Given this list of marker genes LY6G5C, KCNH6, ZBTB20, GADD45B, AAK1, ARRB1, EPS8L1, PDE4B, TM7SF3, PPP1R2C, GALNT13, RGS2, CACNA1A (calcium voltage-gated channel subunit alpha1 A), KREMEN1, DUOXA2, NID1, TMEM156, ART4, TFPI, LRRD1, ZSWIM2 (NCBI Gene Id 151112), XCL1, FHL2, LINC03013 (long intergenic non-protein coding RNA 3013), IL13RA1, SH3D21 (SH3 domain containing 21), TFAP2C, TNFRSF14, TNFSF9, GLULP4, TTC39A, SP5, MYH14, MYO7A, OSBPL5, LINC02478, ATP2B3, PPP1R15A, MYO5B, TRAV24, FAM167A-AS1, SMIM34, ANXA8, ZNF286A, JUNB, UBE2H, DSPP, PER3, ZNF451, MIR214, ENSG00000291156, TRPM5, BBOF1 (NCBI Gene Id 80127, basal body orientation factor 1), TPCN1, LINC02549, CD69, HS1BP3, ZNF594, C4orf3, TRIM8, CDC42EP3, CFAP53, PAPPA, ZNF264, EIF4A1, CD7 (CD7 molecule), NRG2, HOXB1, HLA-DQB1, HLA-DOB, PLXDC1, WIPI1, BTD, HOXB13, ATP2C2-AS1, LLGL2 (NCBI Gene Id 3993), MYLIP, FAM226B, CARMIL3, JSRP1, PURPL, LILRA5, VNN1, TPM3, TRIM22, IQCF5, C1RL, PYHIN1, CD44, FBXO44, PDXP-DT, MR1, PTGS1, KCNIP2-AS1, C1QTNF1-AS1, PSORS1C2, TIAM1 (NCBI Gene Id 7074), GCH1, SIPA1L3, NIPAL2, CTC1, KRAS, UNC13D, IFRD1, HS3ST5, GPATCH2L, GABRA6, CMBL (carboxymethylenebutenolidase homolog), DNAJC4, DCANP1, PLK2, RAB3GAP2, BTNL9 (NCBI Gene Id 153579), MIR133A1, TRIM16, LNCARSR, LINC02352, HIPK2, BIN1 (bridging integrator 1), NHIP (neuronal hypoxia inducible, placenta associated), TTC12-DT, SEMA6A (semaphorin 6A), WDR59, RBM43, ITGAM, ADGRA2, MACROH2A2, DGKA, PRELID2, ACACB, ENPP2, ULBP3, EXOC3-AS1, EP400, CP, NFIB, PTCRA, PRKAA2, MAOA, SESN2, TNFAIP6, SPOCD1, MYLK, CCR5, CIMIP4, APOBEC3G, RCBTB2, LYZ, LINC00520, IGFN1, HBS1L, TSGA10, TNP2, LINC00824, MIR34AHG, ZNF91, TJP3, KRT18P27, SYTL1, FAXDC2, LINC00964, FCRL4, OFD1, UBE2F, ENSG00000240207, TP53INP1, GSDMB, GP6, LCP2, PPIC, STK17B, ARPP21, DYNC1I1, PIM1, CASS4, APOBEC3F, ZBP1, LINC00857, LAMA5-AS1, CCNYL2, ZMAT3, FDXR, IKBKB, HOXC8, ABCB9, LINC00550, TRAV40, CAPN13, CDKN1A (NCBI Gene Id 1026), TPPP2, SGK1, CYP19A1, SHANK1 (NCBI Gene Id 50944), LRP6, SLC10A1, PTAFR (NCBI Gene Id 91527), BBC3, FAM20C, IGHE, SAT1, MIR22HG, CLDN1, RAG2, ALOX5, FER1L5, RNF39, ZNF727, HMCN2, MXD1, DEPP1, DLX2, MPEG1, RRAD, HSD11B1-AS1, GPSM1, CAMTA1, EGFLAM-AS2, ZBED2, LINC02941, MON2-AS1, NACA, IL5, DCBLD2, FER1L4, ABAT, EIF1, CX3CR1, SLAMF8, RAB1A, IGHA1, GATA4, DOCK9-DT, SIX1, CREBRF, NR4A3 (nuclear receptor subfamily 4 group A member 3), JUN, FOXE1, TNFRSF10D, MPDZ, PTGER3, ORM1, BNIPL, DAPK2, IL9R, KLK1, VRK3, TSC22D1, SLC6A19, KIF19, AVPR2, PRKD2, EHMT2-AS1, PLEKHG4B, NEAT1, RNF157-AS1, PLEKHH1, RGS1, CA10 (carbonic anhydrase 10), TMEM202-AS1, AP3B2, CD72, WNT9A, THBS1 (NCBI Gene Id 7057), CCL28, ENSG00000261095, MXD4, HAX1, CFAP47, ZNF396, SIK1, HLA-DQA1, GPR85 (NCBI Gene Id 54329), FLT4, BIRC7, PCDHB12, ZMYND10, ADAMTS1, UCP2, SCARA5, IDS, TMEM171, GRM7, ALDOB, RAB4A-AS1, FAM83E, MNX1-AS1, ARSD (NCBI Gene Id 414), ENSG00000289202, KLHL22, ASS1 (argininosuccinate synthase 1), PLCXD2, ICA1L, FBXL19-AS1, MTNR1A, ENSG00000250230, H2AC25, PCYT1B, MAP3K12, THAP10, CASP3, RTF2, ZNF155, S100A7A, KLF6 (KLF transcription factor 6), POU3F1, POLD4, FAM153A, SORBS2, GDF2, SAMD4A, HAGHL, DPYSL5, OR5V1, SLAMF6, SYNE1, ZFP36L1, F11R, C3orf52, RHEB, PABPC1, PYCARD-AS1, LILRB3, UBR5-DT, LINC01649, UBE2V2, INPP4B, MYH1, IGSF3, POC1B-AS1, PRKG2, CYP4F2, PRM1, SLC2A3, ADIRF, SYT17, PHTF2, PLAAT4, SESN1, ID2, TMT1A, PIK3CA-DT, LINC00929 (long intergenic non-protein coding RNA 929), RBBP6, AQP2, FAS, LNCPRESS1, RORB, SLC22A23, ALDH2, NHSL1, CD27, IL7, IL21, HOXB9, LRRC71, TSC22D3, THBS1-IT1, EML2, SERPINA1, RORA-AS1, AK1, FCMR, CD37, TXNIP, PIERCE2, YPEL5, PTPRS, CCDC13, DUSP1 (NCBI Gene Id 1843), SLC2A12, RNF144B, CALD1, FUT6, CELA1, PCDHA9, SATB1, COL2A1, HPGD, PLAC9, CHIC1, LTBR, TP53TG1, BTG1, SV2C, CASC15, GADD45A, PLIN5, CSRNP1, CADM4, C15orf62, LGALS9, MTCO2P34, NRCAM, APCDD1, TOX, LINC02114, GUCA1C, LINC00092, MIR101-2, PAK5, LINC00951, SERPINA9, ANXA4, FTH1, CASQ2, PCDH11X, GRIK2, LINC00642, LMO2, TALAM1, GLIPR1, IDNK, TOR1AIP2, CASP10, PADI4, TENT5C, MYO1G, LINC01304, NOMO2, IL4R, CAPS, SCIN, ACTR3C, LINC02239, LINC02019, RTKN, SQSTM1, CDC14A, TMEM132D-AS1, ADGRD2, YPEL2, BICDL1, LINC03095, STXBP6, MALAT1, LINC01148, ZNF524, KLF10, HSPB9, ENSG00000225050, ABCC3, SHE, here is a description of the gene set: studied in species Homo sapiens Genes up-regulated in P493-6 cells (B lymphocyte, Burkitt's lymphoma model) upon knockdown of TFRC by RNAi. Overexpression of transferrin receptor 1 (TFRC1), a major mediator of iron uptake in mammalian cells, is a common feature of human malignancies. Therapeutic strategies designed to interfere with tumor iron metabolism have targeted TFRC1. The c-Myc oncogenic transcription factor stimulates proliferation and growth by activating thousands of target genes. Here we demonstrate that TFRC1 is a critical downstream target of c-Myc. Using in vitro and in vivo models of B-cell lymphoma, we show that TFRC1 expression is activated by c-Myc. Chromatin immunoprecipitation experiments reveal that c-Myc directly binds a conserved region of TFRC1. In light of these findings, we sought to determine whether TFRC1 is required for c-Myc-mediated cellular proliferation and cell size control. TFRC1 inhibition decreases cellular proliferation and results in G1 arrest without affecting cell size. Consistent with these findings, expression profiling reveals that TFRC1 depletion alters expression of genes that regulate the cell cycle. Furthermore, enforced TFRC1 expression confers a growth advantage to cells and significantly enhances the rate of c-Myc-mediated tumor formation in vivo. These findings provide a molecular basis for increased TFRC1 expression in human tumors, illuminate the role of TFRC1 in the c-Myc target gene network, and support strategies that target TFRC1 for cancer therapy. Human Gene Set: ODONNELL_TFRC_TARGETS_UP from publication O'Donnell KA, Yu D, Zeller KI, Kim JW, Racke F, Thomas-Tikhonenko A, Dang CV (PMID 16508012)